Given this list of marker genes Cyfip1, Brk1, Fchsd2, Wasf2, Nckap1, Abi2, Wmp, Wasf1, Wasf3, here is a description of the gene set: Any process that activates or increases the frequency, rate or extent of Arp2/3 complex-mediated actin nucleation. studied in species Mus musculus Mouse Gene Set: GOBP_POSITIVE_REGULATION_OF_ARP2_3_COMPLEX_MEDIATED_ACTIN_NUCLEATION